The following is a description of a gene set: Prolinuria Human Gene Set: HP_PROLINURIA Level of proline in the urine anove the upper limit of normal. studied in species Homo sapiens, and this is the list of marker genes: OPLAH, ALDH4A1, SLC6A18, SLC6A20, PRODH, SLC6A19, SLC36A2